The following is a description of a gene set: Human Gene Set: REACTOME_MATURATION_OF_PROTEIN_3A studied in species Homo sapiens Maturation of protein 3a, and this is the list of marker genes: GALNT1, ST3GAL1, ST6GALNAC4, ST3GAL4, ST3GAL2, ST6GAL1, ST6GALNAC2, ST6GALNAC3, ST3GAL3